Given this list of marker genes Tmem59, Pak2, Slc4a7, Vamp3, Pak6, Ralgapa1 (NCBI Gene Id 79457, Ral GTPase activating protein, alpha subunit 1), Arhgdig, Tuba1b, Fam91a1, Pak5, Arhgdib, Pak1, Cav1, Nsfl1c, Lck, Rock2, Wdr11, Rab7 (RAB7, member RAS oncogene family), Rock1, Pak4, Vcp, Osbpl11, Slc1a5, Jup, Rhoh, Dbt, Csk, Lamtor1, Vangl1, Mtr, Arhgdia, Tfrc, Nipsnap2, Zap70, Stom, here is a description of the gene set: RHOH GTPase cycle Mouse Gene Set: REACTOME_RHOH_GTPASE_CYCLE studied in species Mus musculus